The following is a description of a gene set: Regulation of lineage potential and transcriptional priming by Ikaros. New insight is provided into a bivalent regulation of lineage priming in the HSC and its lympho-myeloid restricted progeny the LMPP by the lymphoid lineage-determining factor Ikaros Whereas Ikaros is responsible for the activation of a cascade of lymphoid expression programs and for the establishment of lymphoid potential from the HSC to the LMPP it is also responsible for the repression of stem cell and erythroid genetic programs that are incompatible with further lineage restrictions emanating from the LMPP Human Gene Set: GSE15330_LYMPHOID_MULTIPOTENT_VS_GRANULOCYTE_MONOCYTE_PROGENITOR_IKAROS_KO_DN from publication Ng SY, Yoshida T, Zhang J, Georgopoulos K (PMID 19345118) studied in species Homo sapiens Genes down-regulated in IKZF1 knockout: lymphoid-primed multipotent progenitors versus granulo-monocyte progenitors., and this is the list of marker genes: DAP, IL9, TMEM134, ADAM9, KLHL9, TMEM184B, HOOK2, MTMR4, PDZD11, CCNC, MEF2B, IL6R, MYBL2, CNOT8, MXI1, ERC1, CHST3, RBMS2, PRNP, FKBP11, KLF10, FBXO6, ACP5, STAB1, ACSL4, KIF3A, RFXAP, UBL3, CASQ2, IL17D, ARF4, EMP3, PPP1R3F, ARF6, FURIN (NCBI Gene Id 5123), FES, PLXNA1, RIPK3, LIME1, C1S, SGK1, SERTAD1, TIPARP, ASB17, FRMD8, FCHO1, HVCN1, TMEM163, GALE, AP1G2, RAB11A, XYLT2, DENND10, PPP3CB, PLCG2, PRAF2, SLC16A6, SLC41A1, CYP4A22, PCBP4, FAM50A, ST3GAL4, AEBP2, ADRB3, NFIL3, LSG1, CLIP1, LIF, STK38, MAPK7, TSPO, UNC5C, TXNDC17, DOK1, PTPN1, PMEPA1, BANF1, RALB, NCBP2AS2, PTBP3, CRTAP, RGS10, TLE2, TTL, CDS2, SHCBP1, SLC44A2, EIF6, AHNAK, STAB2, NECAP2, TBC1D19, EMILIN1, SLC35E4 (NCBI Gene Id 339665), DDX54, KCNMB4, RFFL, SPRED1, TM9SF3, GJA1, ACVRL1, EVC, GGACT, KLF9, GABARAP, GORASP2, KCTD17, RELL1, MNT, AKAP12, UNC13A, SLC12A7, SERINC1, PXN, GSTM5, ENPP2, PRR14, PIAS2, FMNL1, TRIP10, MGP, POR, C2CD2L, GFOD2, LRBA, ZNF565, HSPA4L, RPS16, LAMTOR1, MYO10, MGST3 (NCBI Gene Id 9272), SMDT1, IZUMO1R, SGO1, NDST1, EEF2K, CRY1 (cryptochrome circadian regulator 1), CCSAP, MED11, PBX2 (NCBI Gene Id 5089), GM2A (NCBI Gene Id 2760), STX4, RNF130, ATP6V0B, SLC66A1 (solute carrier family 66 member 1), HIF1A, RGCC, AVPR2, EBF1, ANKRD33, HAUS4, TBC1D1, ERCC2, VPS29, HIKESHI, SMTN, UBE2V1, CRYBG3, B3GAT3, SSBP4, GRAMD4, PXK, TXK, IER3, FNDC3A, IFNGR2, SAR1A, CYP39A1, RACGAP1, AGTPBP1, ULK2, GNG2, SDC3, KRT84, SMPD5, CD6, TMED3, PLEC, FOXO1, KLK10, MAPK3, ANXA7, CHST14, ADRA2C, TRPS1, TEX261, MFSD6, GLIPR2, CA13, TNK1, ACOT7, GADD45G, ATOSB, SNAP29, CXCR5, EID1, POU1F1, KIAA1191, ATP6V1D, LGALS3